Given this list of marker genes TUBB3, TUBA4A, TUBA4B, TUBA1C, TUBA3E, TUBA8, TUBA3D, TUBB2B, TUBB2A, TUBA1B, TUBB8B, TUBB8, TUBB4A, TUBA3C, TUBA1A, GJA1, TUBB4B, TUBAL3, TUBB1 (tubulin beta 1 class VI), GJB2, TUBB6, here is a description of the gene set: Following connexon oligomerization, the hemichannels must be transported to the plasma membrane. This has been shown to occur in transport vesicles called "cargo containers". Most of post-Golgi cargo containers have a diameter of of 50- 200 nm. Recently direct transport of connexins to GJ assembly sides has been described. Besides microtuble-dependent trafficking, a microtubule-independent delivery pathway may exist as concluded from studies using the secretory transport inhibitor, Brefeldin A. Reactome Pathway: Transport of connexons to the plasma membrane part of: Gap junction assembly studied in species Homo sapiens